The following is a description of a gene set: studied in species Homo sapiens Any process that modulates the frequency, rate or extent of extrinsic apoptotic signaling pathway in absence of ligand. Human Gene Set: GOBP_REGULATION_OF_EXTRINSIC_APOPTOTIC_SIGNALING_PATHWAY_IN_ABSENCE_OF_LIGAND, and this is the list of marker genes: WWOX, GDNF, EYA3, GFRAL, TNF, TGFB2, PPP1CA, PPP2R1B, EYA1, COL2A1, RIPK1, BCL2L1, PRDX2, KLF4, IL7, C8orf44-SGK3, CX3CL1, FGFR1, GATA1, CTNNA1, RET, IFI6, PPP2R1A, FYN, IL1B, MAP2K5, STRADB, AKT1, SGK3, EYA2, IL1A, EYA4, BCL2, CSF2, MAPK7, INHBA, NRG1 (neuregulin 1), PF4, SNAI2 (snail family transcriptional repressor 2), HTRA2, UNC5B, NF1, MCL1, TERT, HSPA1A, FGF10, SRPX, HSPA1B (NCBI Gene Id 3304)